The following is a description of a gene set: species: Mus musculus Mouse Gene Set: GOMF_TRANSKETOLASE_OR_TRANSALDOLASE_ACTIVITY Catalysis of the transfer of an aldehyde or ketonic group from one compound (donor) to another (acceptor)., and this is the list of marker genes: Tkt, Tktl1, Ilvbl, Taldo1 (transaldolase 1), Tktl2